The following is a description of a gene set: Any process that modulates the rate, frequency or extent of sphingolipid biosynthesis. Sphingolipid biosynthesis is the chemical reactions and pathways resulting in the formation of sphingolipids, any of a class of lipids containing the long-chain amine diol sphingosine or a closely related base (a sphingoid). species: Mus musculus Mouse Gene Set: GOBP_REGULATION_OF_SPHINGOLIPID_BIOSYNTHETIC_PROCESS, and this is the list of marker genes: Samd8, Ormdl2, Sirt3, Sphk1, Abca2, Ccn1, Prkcd, Paqr4, Sphk2, Smpd3, Atg7, Zfp750, Ormdl1, Enpp7 (NCBI Gene Id 404708), Ormdl3, Pla2g6